Given this list of marker genes IFITM3, LSP1, AIMP1, CDC25B (NCBI Gene Id 994), RPS4X (ribosomal protein S4 X-linked), RPS11, GZMA, KLHL6, PYHIN1, PSMB4, GNA15, LGALS3, RPL22, BAK1, PKP3, RPS2, MYO1G, RPS10 (ribosomal protein S10), ARPC5, FUT7, CCL5, MT1A, IFITM2 (NCBI Gene Id 10581), CD48, CD47, LAT2, EIF3I, CLIC1, RPLP0, NOP53, RACGAP1, LGALS1 (galectin 1), RASA3, NUDT21, GIMAP1, RACK1, COX4I1, RPSA, RPL28, MYL6, POLR1D, CRIP1, ATP5PB, RILPL2, RPL24, CORO1A, PHF5A, ARPC3, RBM3, APRT, ABRACL, BSCL2 (NCBI Gene Id 84753), PRR13, EBP, PLP2, CDC42, RPS27L, EEF1B2, EPSTI1, PRELID1, IGBP1, MRPS16, RPL7, MSRB1, EEF2, AP2S1, HMGB2, CSNK2B, CORO1B, NCCRP1, ITGB1, RPL10, RPL29, DAP (death associated protein), GZMK, NRP1, CCT2, ESM1, PLEK, RPL7A, MRPL58, RASGRP2, KXD1, FLOT1, RPL39, PSMD8, GAPDH, PPP1CA, REEP5, RAC2, EIF3H, ESD, COX5B, CLTA, NPC2, ROM1, GLIPR2, ARL6IP5, KLRD1, GIMAP7 (NCBI Gene Id 168537), PYCARD, DHRS1, PGLYRP1, EIF4E2, EIF3F, CCDC12 (coiled-coil domain containing 12), PRDX1, RPS20 (ribosomal protein S20), ITGAX, RPS26, CMTM7, ACTG1, IFITM1, PSME1, GLRX, CARHSP1, RPL4, ARPC1B, ANXA6, GM2A, RPS17, CCR2, PDLIM1, PDLIM2, GLUD1 (NCBI Gene Id 2746), ATP1B3, RPL31 (NCBI Gene Id 6160), GGT1, MRPL30, BTF3 (NCBI Gene Id 689), GMFG, RNH1, GZMB, RPS12, ATP5F1C, ANXA2, LGALS3BP, RPL10A, NACA, here is a description of the gene set: from publication Jiang C, Chao CC, Li J, Ge X, Shen A, Jucaud V, Cheng C, Shen X (PMID 38455971) Human Gene Set: JIANG_MELANOMA_TRM6_CD8 studied in species Homo sapiens Tissue-resident memory T cells (TRM) are a specialized T cell population residing in peripheral tissues. The presence and potential impact of TRM in the tumor immune microenvironment (TIME) remain to be elucidated. Here, we systematically investigated the relationship between TRM and melanoma TIME based on multiple clinical single-cell RNA-seq datasets and developed signatures indicative of TRM infiltration. TRM infiltration is associated with longer overall survival and abundance of T cells, NK cells, M1 macrophages, and memory B cells in the TIME. A 22-gene TRM derived risk score was further developed to effectively classify patients into low- and high-risk categories, distinguishing overall survival and immune activation, particularly in T cell-mediated responses. Altogether, our analysis suggests that TRM abundance is associated with melanoma TIME activation and patient survival, and the TRM-based machine learning model can potentially predict prognosis in melanoma patients.